The following is a description of a gene set: electronically inferred by orthology from the curated human pathway Reactome Pathway: Intra-Golgi and retrograde Golgi-to-ER traffic studied in species Mus musculus This event has been computationally inferred from an event that has been demonstrated in another species.<p>The inference is based on the homology mapping from PANTHER. Briefly, reactions for which all involved PhysicalEntities (in input, output and catalyst) have a mapped orthologue/paralogue (for complexes at least 75% of components must have a mapping) are inferred to the other species. part of: Membrane Trafficking, and this is the list of marker genes: Rab39, Racgap1, Alpi, Tubb2b, Usp6nl, Tmed9, Rab3gap2, Tubal3, Copg2, Rab6a, Rint1, Cyth3, Arfip2, Cog8, Cog7, Copb2, Klc3, Kif26a, Golga4, Arf5, Kif1b, Dynll1, Tmed3, Actr10, Snap29, Dync1li2, Tuba1c, Kif2b, Stx18, Klc4, Arcn1, Rab1b, Kdelr3, Tuba1a, Kif18b, M6pr, Igf2r, Kif20a, Tubb4b, Pla2g6, Pafah1b3 (platelet-activating factor acetylhydrolase, isoform 1b, subunit 3, NCBI Gene Id 18476), Kif3c, Rab30, Plin3, Copb1, Arfgap2, Kdelr2, Kifap3, Gcc1, Kdelr1, Agpat3 (1-acylglycerol-3-phosphate O-acyltransferase 3), Galnt1, Tuba8, Cyth1, Tuba4a, Tuba3b, Vamp4, Dctn6, Rab1a, Tuba1b, Kif21a, Kif12, Cyth4, Copg1, Nbas (NCBI Gene Id 71169), Rab36, Arf1 (ADP-ribosylation factor 1), Tubb4a, Kif27 (kinesin family member 27, NCBI Gene Id 75050), Tmed10, Rab18, Kif5b, Cenpe, Nsf, Bicd2, Actr1a, Kif2c, Vps54, Rab9b, Kif9, Dctn1 (NCBI Gene Id 13191), Tubb6